The following is a description of a gene set: species: Homo sapiens Human Gene Set: GOBP_POLYSACCHARIDE_METABOLIC_PROCESS The chemical reactions and pathways involving a polysaccharide, a polymer of many (typically more than 10) monosaccharide residues linked glycosidically., and this is the list of marker genes: WDR45, TGFB1, IGF2, GYG1, INS, G6PC1, EGF, MIR15B, PPP1R3F, PHKA1, SORBS1, PHKB, PPP1R2, PPP1R3D, PPP1R1A, GCGR, AGL, GBE1, AKT1, COMT, GSK3B, PPP1R3A, PRKAG2, RUBCNL, PDGFB, HAS2, PPP1R2B, WIPI2, EXT1, NDST1, PHKA2, PPP1CB, IL6ST, HMGB1, POMC, HAS3, IRS2, PTH, ATG12, MIR195, EPM2A, RB1CC1, GYS2, AP2A1, ATG2B, CHIT1, ADCY10, ENPP1, CHIA, STK40, INPP5K, ATG2A, CHST7, HAS1 (hyaluronan synthase 1), AKT2, KHK, GNMT, SMPD3, GALNT3, NR1D1, NHLRC1, MIR1271, GYG2, PHKG2, ATG3, PHLDA2, PPP1CC (NCBI Gene Id 5501), PPP1R3B, PPP1R3E, FUT9, PPP1CA, PER2, LEPR, GRB10, GYS1, CLTC, DYRK2, CHST1 (carbohydrate sulfotransferase 1), PRKAG3, PGM2, PYGL, PFKM, PPP1R2P1, STBD1, PYGM, WIPI1, ACADM, GSK3A, PASK, PYGB, GABARAPL1, MGAM, PHKG1, PCDH12, GCK, IGF1, NPC1, UGP2, INSR, IRS1, GAA, NFKB1, EPM2AIP1, PPP1R3G, WDR45B, EXT2, SELENOS, PPP1R3C